The following is a description of a gene set: from publication Chen Y, Wang X (PMID 31504780) Human Gene Set: MIR3675_3P Genes predicted to be targets of miRBase v22 microRNA hsa-miR-3675-3p in miRDB v6.0 with MirTarget v4 prediction scores > 80 (high confidence targets). studied in species Homo sapiens, and this is the list of marker genes: FAM20A, GAB1, ADGRG4, TRIL, LIMA1, SMIM3, MPLKIP, SLC50A1, CPOX, LURAP1, SAMD4A, DNAJB4, SGO1, AGFG1 (NCBI Gene Id 3267), MMP12, DCLK1, ACYP1, NPR3, USO1, FAM151B, FLT1, MTFMT, CISD2, RTKN2, FAM199X, SAMD9, EIF2AK3, MSH4, GOLPH3L, TRAPPC9, EPB41L1, OTUD6B, BCAT1, ADRB2, ADM, SCN8A, RB1, PSTPIP2, CAMTA1, NDNF, ACSL6, SCN7A, LYRM7, FZD3, CDRT4, PCLO, ORC2, CASK, ENAH, ADAMTS2, PIKFYVE, LHFPL1, MCTP1, RNF146 (NCBI Gene Id 81847), AIRIM, H2AZ2, SLC4A8, USP12, NONO, ANXA1, KIAA0825, PHF8, TAC1, SCHIP1, HDDC2, GNG10, ERO1B, ZSCAN12, TVP23C-CDRT4, ZNF225, PRNP, PDP2, LGR5, CASZ1, ENSA, TENM3, IQCJ-SCHIP1, DNAJC25-GNG10, ENC1, RBFOX1, SMAD1, ATP7A, ZC3H12C, CNTN1, BCL2L11, SLC1A3, MAFK, ALCAM, DKK2, SEC61G, FZD7